The following is a description of a gene set: The role of Nef in HIV-1 replication and disease pathogenesis Human Gene Set: REACTOME_THE_ROLE_OF_NEF_IN_HIV_1_REPLICATION_AND_DISEASE_PATHOGENESIS studied in species Homo sapiens, and this is the list of marker genes: ARF1, AP1M1, B2M, CD4, ATP6V1H, AP2A1, FYN, AP1M2, RAC1, AP2S1, ELMO1, HLA-A, PAK2, LCK, HCK, AP1S2, AP2A2, AP2B1, AP1B1, DOCK2, CD8B, CD28, AP1S1, AP1S3, AP1G1, CD247, AP2M1, PACS1